The following is a description of a gene set: studied in species Mus musculus Mouse Gene Set: GOBP_PROTEIN_POLY_ADP_RIBOSYLATION The transfer of multiple ADP-ribose residues from NAD to a protein amino acid, forming a poly(ADP-ribose) chain., and this is the list of marker genes: Tnks, Macroh2a1, Parp1, Tnks2, Parp2, Parp10, Parp14, Enpp1